The following is a description of a gene set: Any process that modulates the frequency, rate or extent of cAMP-dependent protein kinase activity. Human Gene Set: GOBP_REGULATION_OF_CAMP_DEPENDENT_PROTEIN_KINASE_ACTIVITY studied in species Homo sapiens, and this is the list of marker genes: ADIPOQ, MST1, SIRT1, RAPGEF2, PKIA